The following is a description of a gene set: Development of T-cells provides a unique opportunity to study cell-fate determination due to the accessability and the well defined stages of developmental stages. In order to understand the genetic programs underlying fetal and adult T‑cell fate specification we subjected highly purified fetal and adult T-cell progenitor populations to a genome‑wide transcriptional analysis. The aim was to identify molecular elements that govern T-cell fate specification as a whole but ultimately to isolate elements that were specific for a given population in a specific developmental window. from publication Belyaev NN, Biró J, Athanasakis D, Fernandez-Reyes D, Potocnik AJ (PMID 22581009) Human Gene Set: GSE24142_ADULT_VS_FETAL_DN3_THYMOCYTE_DN studied in species Homo sapiens Genes down-regulated in comparison of adult DN3 thymocytes versus fetal DN3 thymocytes., and this is the list of marker genes: PHLDA1, FBLN1, ARID3A, PCBP4, SLCO5A1, ERGIC1, LMO7, MMP17, CAPN3, ZMAT5, G0S2, SUSD4, PTPN13, SETD4, STK39, WSB2, PODXL, MFHAS1, RGL3, CRCT1, DDC, MORC1, CHD7, P2RX1, TNNT1, RYR1, RDH10, FBLN2, PDLIM5, SLC45A3, TEFM, CREB3L2, CXCR5, BID, TOM1L1, NFIL3, GRB10, SEPTIN11, EPHX2, LIPG, ELL2, BEX4, HAAO, ZNF14, GIMAP4, AMPH, KRT18, ID2, SCAMP1, HOXB13, CUX2, CPSF4L (NCBI Gene Id 651471), KDM7A (lysine demethylase 7A), ZNF808, DENND2D, SYNGR2, TASP1, DSG2, STC2, BCL2L14, LY86, TIMP2, IGF1R, LGMN, TRIB2, CERS4, UNC119, TRAF5, MESP2, BMAL1, ELAVL4, ITGAV, AGFG1, RPL39L, PLPP1, PLIN2, PRMT7, TPST2, IFTAP, PAWR, SH3BGRL2, M1AP, SFRP2, TJP1, BASP1, PROS1, CRTAC1, GADD45G, ACAA1, DCAKD, KCNAB2, RYK, IGF2BP1, BAMBI, PTPRO, ADAM2, FGD6, SPIB, SNRK, MT1E, PSTPIP2, GNAI1, CDK5RAP2, ASNS, CD2, SOX6, PLEKHO1, GATA1, RAB20, TXK, SNF8, SWSAP1, CLVS1, CYB5A, KIFC3, ZCCHC18, SLC2A3, CTNND2, CYB561, TLE6, HOOK2, ARL4C, SELENOS, SH3GL3, P4HA2, ADRB2, TM7SF2, BMPR1A, CD82, PHYH, INSL5, STAT1, CASK, WDR33, HUNK, CAPG, TBPL1, SRSF9, H3C4, PPARG, ACYP2, PSME4, SRC (SRC proto-oncogene, non-receptor tyrosine kinase), CA8, NLRP6, DSTN, IZUMO1R, SEPTIN4, B4GALNT2, SIDT1, NSDHL, APOE, B3GNT8, ITGAE (NCBI Gene Id 3682), FDFT1, DLST, PKIA, CLEC11A, ICOS, ARVCF, RND2, KERA, MEIS1, RACK1, EEF1E1, CBLN1 (cerebellin 1 precursor), SCARA3, APTX, GEM, QNG1, TNFSF11, FDPS, TNFRSF9, IL10, FICD, GRB7, TEN1, SERPINC1, PTPN14, H2BC3, DUSP1, NRARP (NCBI Gene Id 441478), PABPC4, NLN, ANAPC16, MXD1, IL5RA, TIRAP, GALE (NCBI Gene Id 2582), GPR34, FAM118B, ZDHHC2, KLHL7, CDC42EP1, ARID5B, LYPLAL1, CTTN, PGAM2, FLNB, CENPV